Given this list of marker genes MANEA, MGAT1 (alpha-1,3-mannosyl-glycoprotein 2-beta-N-acetylglucosaminyltransferase), MAN1A1, MAN1A2, MAN1C1, here is a description of the gene set: part of: Transport to the Golgi and subsequent modification Reactome Pathway: N-glycan trimming and elongation in the cis-Golgi After the transport of the glycoprotein to the cis-Golgi, the pathway of N-glycosylation bifurcates. Some N-glycans can be moved to subsequent steps of the secretory pathway without further modifications, or alternatively, with the removal of a few mannoses (Oligo Mannoses pathway). In yeast and other unicellular species, a series of mannose residues are added (High Mannoses pathway). The presence of this modification is a major obstacle to the production of pharmaceutical drugs in yeast, where the HighMannose pathway must be inhibited or modified in order to avoid the presence of high mannose xenoglycans.<br>The first N-glycan modification step is the trimming of up to four mannoses by one of three mannosidase enzymes. Moreover, Glycoproteins that have not entered in the Calnexin/Calreticulin cycle or that have not had their glucose residues trimmed earlier in the ER, can enter the main pathway here due to the existence to an alternative route catalyzed by the enzyme Endomannosidase I<br> studied in species Homo sapiens